The following is a description of a gene set: Human Gene Set: MIR3679_3P species: Homo sapiens from publication Chen Y, Wang X (PMID 31504780) Genes predicted to be targets of miRBase v22 microRNA hsa-miR-3679-3p in miRDB v6.0 with MirTarget v4 prediction scores > 80 (high confidence targets)., and this is the list of marker genes: ELOVL5, NSD2, PPP4R3A, AGMAT, CAMK2G, ELAVL2, STXBP5, KRTAP3-2, BCL9, OSBPL3, RO60, NSD3, KIAA0319, PRCD, APLNR, FRMD4A, SOX4, GABARAPL1, LRRC8E, NCOA2, PLEKHF2, MTAP (NCBI Gene Id 8008), OTUD7B (NCBI Gene Id 56957), NCAPH, CHML, CYP27C1, NCOA1, RNASE13, USP29, DPH2, TMTC1, MED20, TIAL1, C11orf58 (chromosome 11 open reading frame 58), HACD1, PRSS12, FST, SELENOT, HLA-DPA1, ZDHHC17, TP53AIP1, SET, ILRUN, TATDN2, ZNF263, SLC16A6, PTGDR2, FYN, SOCS4, LYSET, TRIM44, HOXA10, VEZT, IRX2, IGF1R, BCL11A, CDR2, HAUS6, MGAT5B, AKAP13, PARD6B, NAA15, PPM1B, ZNF217, MRPS24, GPX7, JADE3, MKLN1, SPON1, KLF7, OSTF1, MEF2A, VPS13D, TMED2, XPR1, SCN8A, KMT2A, MACO1, B2M, CTPS1, ZNF37A, INTS6, ILK, UNG, ELAVL4, ZNF148 (NCBI Gene Id 7707), PTGR3, ABCB5, CFI, ZMYM2, GPBP1L1, PDCD6IP, NUFIP2, RC3H1, PM20D1, SCARA5, AACS, CCND2, TNFSF10, CCN2, MARCHF7, KPNA1, HEBP1, U2SURP (U2 snRNP associated SURP domain containing), HIPK1, GEM, NFAT5, ZFP36L1, ITGA2, PSMD11, CLTC, XG, RFC2, EPSTI1, RPP30, MKNK2, CPSF6, BACH2, LRCH2, LONRF3 (LON peptidase N-terminal domain and ring finger 3), HYCC2, TNS1, GALNT13, DNAAF2, FUBP1, TMEM178B, MTA3, USP9Y, MED23, SPTLC2, SMAD2, EPHA4, DTWD1, UGT8, C1QBP, TNFAIP8L2, CD160, PLEKHA1, MCTP2, RUFY3, AAK1, SSBP3, ELMOD2 (ELMO domain containing 2), B3GALT2, UBE2K, NRXN3, NALF2, APH1A, AKAP6 (A-kinase anchoring protein 6), R3HDM1, SIK2, MSL1, OPHN1, CTNNA2, MED22, NUBPL, TPD52L2, ADAT2 (adenosine deaminase tRNA specific 2), TMEM167B, TNRC18, TOX2, SLC25A37, GLIS3, CACNA1C, ARHGAP19